Given this list of marker genes Prkca, Tnfsf13, Xpo1, here is a description of the gene set: electronically inferred by orthology from the curated human pathway Reactome Pathway: HuR (ELAVL1) binds and stabilizes mRNA part of: Regulation of mRNA stability by proteins that bind AU-rich elements studied in species Mus musculus This event has been computationally inferred from an event that has been demonstrated in another species.<p>The inference is based on the homology mapping from PANTHER. Briefly, reactions for which all involved PhysicalEntities (in input, output and catalyst) have a mapped orthologue/paralogue (for complexes at least 75% of components must have a mapping) are inferred to the other species.